The following is a description of a gene set: studied in species Homo sapiens Combined immunodeficiency Human Gene Set: HP_COMBINED_IMMUNODEFICIENCY A group of phenotypically heterogeneous genetic disorders characterized by profound deficiencies of T- and B-cell function, which predispose the patients to both infectious and noninfectious complications., and this is the list of marker genes: BCL11B, LIG4, PIK3CD, XRCC4, TTC7A, DOCK2 (NCBI Gene Id 1794), IRF2BP2, RAG1, NFKB2, IKZF1, IL2RG, JAK3, BUB1B, IL7R, ADA, ICOS, TNFRSF13B, POLD3, DCLRE1C, TNFRSF13C, DIAPH1, PNP, CD19, ACP5, CHD7, RMRP, RAG2, MS4A1, KNSTRN, CD3D, ICOSLG, PGM3, AK2, PRKDC, EXTL3, MGAT2, CR2, PI4KA, MTHFD1, NFKB1, FOXN1